Given this list of marker genes Rap1a, Gria2 (glutamate receptor, ionotropic, AMPA2 (alpha 2)), Rfx4, Dscam, Pde7a, Paip2, Arhgap6, Fgfr3, Dab2, Ppp1r14c, Car11, Ube2b, Gas2l1, Slk, Tbc1d15, Trpm1, Stc1, Bhlhb9, Unc80, Atp11a, Irak2, Sfi1, Rbm12, Zfhx3, 1110032F04Rik, Ctnnd2 (NCBI Gene Id 18163), Serbp1, Zfx, Cstf2, Ctnnbl1, Cpeb4, Hivep2, Syt1, Ralgapb, Ankrd27, Lgr4, Pabpc4l, Rexo2, Mthfd2l, Tmcc1, Krba1, Uty, Meis2, Akap9, Nfe2l1, Smpd4, Pip5k1b, Plppr4, Atl1, Eif5a2, Nkain3, Cnp, Amer2, Stk26 (serine/threonine kinase 26), Cers6, Mcidas, Ythdf2, Ppp2r1b, Bclaf1, Lsm14a, Tex16, Ly86, Gcg, Skil, Rab23 (NCBI Gene Id 98704), Zfhx4, Cavin1, Fam184b, Ptprm, Ube2k, Six3, Cdk13, Ahcyl2, Crmp1, Zfp786, Clock, Znrf3, Onecut2, Atl3, Krtap9-21, Ralyl, Fam168b, Msi2, Cep170, Zfp839 (NCBI Gene Id 72805), Camk1d, Mettl3, Rnft1, Pde4b, Hoxc4, Il6st, Gcsam, Chd1 (NCBI Gene Id 75119), Zkscan8, Gabrg2, Peak1, Setd3, Wdr36, Tex2, Enpep, Kcnv2, Kctd9, Timd6, Itfg1, Dkk2, Rbm15, Tmem181a, Pdcd4, Ttc3, G6pc1, Them4, Eda, Kif21a, Anxa4, Cacna1h, Map4k5, Cdr2, Wipf1, Hus1, Slc17a6, Ppp3ca, Fryl, Supt7l (NCBI Gene Id 77725), Trpm3, Hoxd1, Ror1, here is a description of the gene set: from publication Chen Y, Wang X (PMID 31504780) Mouse Gene Set: MIR_7223_5P studied in species Mus musculus Genes predicted to be targets of miRBase v22 microRNA mmu_miR_7223_5p in miRDB v6.0 with MirTarget v4 prediction scores > 80 (high confidence targets).